The following is a description of a gene set: A kind of ataxia that affects movements of the extremities. Limb ataxia studied in species Homo sapiens Human Gene Set: HP_LIMB_ATAXIA, and this is the list of marker genes: CWF19L1, PRKCG, VAMP1, ATXN10, PMP22, MSTO1, RUBCN, CSTB, AFG3L2, MTPAP, SCARB2, PRNP, CXCR4, UBA5 (ubiquitin like modifier activating enzyme 5), SPTBN2, PRDX3, TPP1, ATXN1, SQSTM1 (sequestosome 1), ELOVL5, JAM2, ATXN2, CLCN2, MME, SPG7, KCND3, FAT2, CP, SDHA, BCL11A, VPS13D, SCN1B, NKX6-2, CAPN1, VPS41, SLC9A1, CYP7B1, MPZ, GRID2, GBA1, WASHC5 (NCBI Gene Id 9897), UBAP1, FXN, FGF14 (NCBI Gene Id 317685), PDYN, NEFL, SETX, TGM6, SYNE1, TTC19, NOP56, TBC1D24, ATN1 (NCBI Gene Id 1822), EEF2 (eukaryotic translation elongation factor 2), ATXN3, FGF12, TTBK2, GPRC5B, ENSG00000288330, ANO10, TBP (TATA-box binding protein), SCYL1, TMEM240, SIL1, COQ4, TBC1D23, XRCC1, POLG, SYT14, BEAN1, GJB1, SLC30A9, ELOVL4, PLD3, APTX, STUB1, WWOX, PEX10, COX6B1, MAN2B1, ATXN8OS, PRICKLE1, PMPCA, RTN2, TTR, RFC1, CERS1, KCNC3, COQ2, ABCD1, ITPR1, VRK1